Given this list of marker genes Scn10a, Aak1, Baiap2l2, Vps33a, Cltc, Sclt1, Vps41, Clta, here is a description of the gene set: species: Mus musculus Mouse Gene Set: GOCC_CLATHRIN_COMPLEX A protein complex that consists of three clathrin heavy chains and three clathrin light chains, organized into a symmetrical three-legged structure called a triskelion. In clathrin-coated vesicles clathrin is the main component of the coat and forms a polymeric mechanical scaffold on the vesicle surface.